The following is a description of a gene set: Hypoplasia of the cerebellum, pontine nuclei, and inferior olivary nucleus. Human Gene Set: HP_OLIVOPONTOCEREBELLAR_HYPOPLASIA species: Homo sapiens Olivopontocerebellar hypoplasia, and this is the list of marker genes: POMK, PMM2, TSEN54, POMGNT1 (protein O-linked mannose N-acetylglucosaminyltransferase 1 (beta 1,2-)), POMT2, RTTN, PPP2R1A, POMT1, GMPPB, MINPP1, ATXN2, FKRP, TOE1 (target of EGR1, exonuclease)